The following is a description of a gene set: The CRY:PER:kinase complex represses transactivation by the BMAL:CLOCK (ARNTL:CLOCK) complex Human Gene Set: REACTOME_THE_CRY_PER_KINASE_COMPLEX_REPRESSES_TRANSACTIVATION_BY_THE_BMAL_CLOCK_ARNTL_CLOCK_COMPLEX studied in species Homo sapiens, and this is the list of marker genes: PER3 (NCBI Gene Id 8863), NR1D1, CLOCK, NPAS2, CSNK1E, CREBBP, CRY2, CSNK1D, PER2, PER1, BMAL1, RORA, KMT2A (lysine methyltransferase 2A), CRY1